The following is a description of a gene set: Active immunotherapy is a promising strategy for anti-angiogenic cancer therapy. Recently, we have reported that a vaccine using human umbilical vein endothelial cells (HUVECs) induced specific anti-endothelial immune responses in the most of immunized patients, and resulted in tumor regression in some patients with recurrent malignant brain tumors, whereas not in colorectal cancer patients. In this study, we hypothesized that non-hypoxic perivascular tumor associated macrophages (TAMs) in colorectal cancer, but not in glioblastoma, might negatively alter the therapeutic efficacy of anti-angiogenic active immunotherapy. To test this hypothesis, we examined global gene expression profiles of non-hypoxic macrophages stimulated in vitro by soluble factors released from tumor cells of human glioblastoma U-87MG (‘brain TAMs’) or colorectal adenocarcinoma HT-29 (‘colon TAMs’). species: Homo sapiens Human Gene Set: GSE18804_SPLEEN_MACROPHAGE_VS_BRAIN_TUMORAL_MACROPHAGE_UP Genes up-regulated in macrophages: control versus glioblastoma conditioned., and this is the list of marker genes: EPB41, NLRP11, ARRB1, PRRX1, CXCL10, COL27A1, PRKRA, MYOF, SNHG10, TOP1, LSM11, CASC3, CSRNP1, KCNK2, ZNF92, TAC1, MSH4, ZNF674-AS1 (ZNF674 antisense RNA 1 (head to head)), TNFAIP3, WDR48, RIF1, BASP1, ANXA2, UBE2QL1, GPNMB, NFKBIA, POLR1A, FARSB (NCBI Gene Id 112957), RTN1, SKA2, TNC, ATF3, CCN3, ZC3H8, ABCA8, MT2A, TIGD1, ZBTB5, MAMLD1, SDC4, TRIM6, HEXIM1, JUN, AOC2, OPTN, LRTM2, RRAS, MT1HL1, RIMS1, NRDE2, ULK4, NACAD, DDX24, GRIK3, APEX1, PLPPR1, RASGRF2, UPP1, SPC25, CGA, CXCL6, CXCL2, PSMB5, GRM8, EDNRB, GCC2, FOXN3, CXCL3, DHRS2, PLEK2, MT1H, AKR1C3 (NCBI Gene Id 96424), BLMH, BRD7P3, PCSK1, TEX14, C1GALT1, TXNRD1 (NCBI Gene Id 7296), RHOU (ras homolog family member U), AKR1C1, EIF2B2, VPS11, TPST1, MLANA, NEDD4L, FIGN, CCDC150 (NCBI Gene Id 91531), FAM177A1, FBXO34, PTGFR, ANXA2P2, SAMD5, CTTNBP2NL, PRLR, TCEAL7, CALCB, GSPT2, ID3, EFCAB11, CREB5, ABLIM2, TRUB2, SCIN, ZFP62, MT1X, VAMP1, LRRN1, DUSP1, DMRT1, TMEM106B, SNX8 (sorting nexin 8), TRIP12, KLHL7, LINC01551, NEK9, SSR4, TSPAN7, SALL2, SYTL5, SAAL1, BCL11B, MSX2, ARMCX5, TIFA, ZNF107, CCL2, MAP3K8, HSPB8, RPL7A, PTGS2, SNAI2, NUDCD3, MRPS31, CCL20, HJURP, EDIL3, XRCC5 (X-ray repair cross complementing 5), HIF1A, AGPS, IER3 (immediate early response 3), SPOCK1, LIN7A, BCS1L, ID1, MYRIP, DUSP16, ZCCHC12, MAPK8IP1, RHOF, KRIT1, NDRG2, LGALS3, SAMM50, BOD1L1, GHR, VAMP7, PSME1, PPP2R2B, SYNGR4, APOBEC3B, IL32, ZNF211, AKR1C2, TAFA2, DDX60L, ACVR1C, KIF4A, BUB1, PLAAT3, CHSY3 (NCBI Gene Id 337876), EIF4G3, DNER, LINC00692, FITM2, KRT18, LRATD1, MSL1, FAM111A, TFPI2, DCAF4L1, PHF19 (NCBI Gene Id 26147), TOP2A, HNMT, PGR, BMP2, ETS2, CYCS, RACK1, SAMD9, SRSF1 (NCBI Gene Id 650453), TAF5, GALNTL5, SLC2A3, MARCHF7, VIM